The following is a description of a gene set: Macrophage markers Human Gene Set: WP_MACROPHAGE_MARKERS studied in species Homo sapiens, and this is the list of marker genes: CD163, CD74, CD83, F3, CD68, LYZ, CD86, RAC2, CD14